Given this list of marker genes TXNL4A, SAFB, PTGES3, SRSF1, MAPRE1, RAD54L, GOT2, SSRP1, SSBP1, NDUFB3, TCP1, BAZ1B, CCT5, RUVBL2, TYMS, CS, VDAC1, XRCC5, MFAP1, PPM1G, MTREX, DLGAP5, ATP5MC3, ATP5PO, SNRPA, NUDC, TRA2B, SPAG5, LBR, BUB1, PABPC4, HNRNPU, LRPPRC, MCM6, NAE1 (NEDD8 activating enzyme E1 subunit 1), TFDP1, CHERP, ESD, NONO, STMN1, PRKDC, GNB1, SRRM1, ESPL1, MCM2, CENPF, HNRNPA2B1, TOMM70, PARP1 (NCBI Gene Id 142), SNRNP200, GPN1 (NCBI Gene Id 11321), HNRNPD, KIF11, NSD2, DNMT1, LSM2, HAT1, RMND5A, ATP5PF (ATP synthase peripheral stalk subunit F6), FEN1, SMC1A, MCM3, RRM1, SLBP, HNRNPM, G3BP2, H2AZ1, TUBA3C, NUDT1, HDAC2, DUT, ZWINT, CHAF1A, LMNB2, GTF2A2, KHDRBS1, IARS1, USP1, IMMT, HADH, HNRNPR, FH (NCBI Gene Id 83748), VDAC2, SMC3, KHSRP, NASP, BUB3, HDDC2, PPP1CC, MSH2, XPO1, POM121, DNAJC9, HSPE1, ANP32A, TARS1, R3HDM1, YARS1, RFC4, HCFC1 (NCBI Gene Id 8267), AFG3L2 (NCBI Gene Id 573970), PMEL, here is a description of the gene set: Human Gene Set: MORF_RRM1 Neighborhood of RRM1 ribonucleotide reductase M1 polypeptide in the MORF expression compendium species: Homo sapiens Neighborhood of RRM1